The following is a description of a gene set: An anomaly in the development of the embryo, that is, of the early developmental stage of development that follows the fertilization of an egg by sperm. Abnormal embryonic development Human Gene Set: HP_ABNORMAL_EMBRYONIC_DEVELOPMENT species: Homo sapiens, and this is the list of marker genes: IQCN, CHEK1, FBXO43, REC114, BTG4, PADI6, ZFP36L2, TRIP13